The following is a description of a gene set: Genes in the cancer module 332. studied in species Homo sapiens Human Gene Set: MODULE_332, and this is the list of marker genes: MFHAS1, NUFIP2, ILF3, ARGLU1, PUM2, ERCC5, RBM39, GTF3A, EWSR1, SNX4, SUCLA2, TINCR, HAUS1, ZBED5, RB1, HMGB1, TXNDC16, SRSF9, NAA16, WDR47, NPPA (natriuretic peptide A), PCBP2, DIS3, CUL4A, DGCR5, HSPBP1, IPO5, STK24, TPP2, EML4, NR4A1, USPL1 (NCBI Gene Id 10208), DCAF8, PIBF1, ISG20, CASP3, RRM1, GTF2F2, MKI67, XPO4, SUPT20H, SRSF6, UCHL3, MYC, OBI1